The following is a description of a gene set: Human Gene Set: GOBP_POSITIVE_REGULATION_OF_INTRACELLULAR_SIGNAL_TRANSDUCTION species: Homo sapiens Any process that activates or increases the frequency, rate or extent of intracellular signal transduction., and this is the list of marker genes: GDF5, ERBB2, RAF1, RB1CC1, TLR4 (toll like receptor 4), IKBKG, SNW1, MID2, UCN, S100A4, F2RL1, BMP5, ERBB4, SLC8A2, CD27, LRRK2, GAREM1, CARTPT, IRAK4, MUL1, IL18, GPS2, SERPINA12, NFAT5, PTK2, MAP2K6, TGFB2, FPR2, AR, ADGRV1, AGER, VDR, LIF, FLCN, CASP8, GPNMB, BTK, BBC3, KNL1, EGFR (epidermal growth factor receptor), PTBP1 (polypyrimidine tract binding protein 1), PTPRC, RPL11, NMNAT1, ATR, PECAM1, MARCHF5, NGF, TRIM26, EGF, ARFGEF1, PRXL2C, CDCA8, HTR6, SLC9A1, FYN, MN1, KLHDC10, CARD10, C1QBP, CRACR2A, ING4, TNFSF11, MIF, ENG, PARK7 (Parkinsonism associated deglycase), ERFE, PIP4P1, ALS2, EEF1E1, SLAMF1, CUL3 (cullin 3), KL, BMP6, RICTOR, MADD, DSTYK, ATOH8, CDK5RAP3 (NCBI Gene Id 92989), FGF21, MAP2K1, TICAM2, PPM1A, PTPN11, OASL, FRMD1, DCN, TRIM5, XIAP, C1QTNF4, DOK4, SEMA4D, LATS2, PUM2, CCN2, FGB, TNFRSF1A, FRMD6, MOS, ZBTB7B, RPS7, PIAS4 (protein inhibitor of activated STAT 4), ADORA1, ATAT1, ADCYAP1, PDGFB, LMO3, TPBG, CCL5, WLS (NCBI Gene Id 79971), SHISA5, PIK3CG, HAND2, GDF7, CTNNB1, GADD45B, SMARCA4, CD3E, GUCA1A, MFHAS1, TRIM13, NLRP3, SPRING1, MMP2, MYOC, WNT7B, NPY, HDAC6, RASSF2, TLR8, FAM110C, PPP3CC, HDAC3, IRAK1, MIR126, C5AR1, SIRT1 (sirtuin 1, NCBI Gene Id 23411), TFG, NTS, DVL3, GADD45G, MTDH, TERF2IP, RPS6KB1 (NCBI Gene Id 6796), ABCA7, SH2B1, KLF2, S100A13, MAP4K1, STK39, DDX60, MBIP, DDR2, HLA-DRB1, TRIM22, PTPRJ, GSDME, AJUBA, BOK, LILRA5, GJA1, NOTCH2, BANK1, SEMA5A, TRAF6, FN1, CASTOR1, PSMA6, JUND, P2RX7, AMH, FGF19, FGA, AGT, DIRAS2, MIR181D, TRIM32, ALOX15, NR2C1, GNAI2, EXTL3, STK4, CARD9, COL3A1, PAK1, KIAA0319, IQGAP3, ABRA, IL1A, TWSG1, PDCD4, USP9X, BCLAF1 (BCL2 associated transcription factor 1), LIN28A, PRKD2, FLT1, TP53BP1, CASP1, RWDD3, ATP2C1, P2RX4, SLC30A10, HTR2B, BMPR1A, USP32, LGALS9, ALOX12B, FGF17, ADIPOQ, RET, IL6, AKT1, MIR181A2, CSNK1A1, CHI3L1, PRKACA, CLEC6A, SASH1, CLU, EDN3, PRKCE, FNIP2 (NCBI Gene Id 57600), SHOC2, STK25, GFRAL (NCBI Gene Id 389400), NOD2, USP17L2, CCR1 (C-C motif chemokine receptor 1), LMCD1, RAP1B, PTPN6, BCL10, MAP3K7, VAV2, BRCC3, SESN2 (sestrin 2), MARCO, RTKN2, CD4, NRXN1 (neurexin 1), TAB3, FABP5 (NCBI Gene Id 92424), UBE2N, ATF6, MIR182, ARHGEF10, MERTK, S100A12, GPR37L1, SEMA3E, HCST, CCR7, AGO3, NPY5R, GPR62, CAT, F11R, DUSP19, IGFBP5, RPS20, MLST8, VAV1, PELI2, FLT3, GPR55, LRRC19, RIT2, SOX2, RASGEF1A, PIM1, FGFR4, FLOT2, HAVCR2, BMP2, SPPL3, TRIM55, IGF2, FXR1 (FMR1 autosomal homolog 1), PYCARD, CBL, PDGFD, DDX1, TAOK1, GBP2, LAMTOR1, EPO, MYD88, GREM1, CYP27B1, CXXC5, PDE8A, PML, PDGFC, IL19, VAPA, DKK1, LAMTOR5, HTT, KMT2D, PLXNB1, PROS1, ADORA2A (adenosine A2a receptor), MAP3K11, PRL, PTPN22, DGKQ, DDX5, BMPR2, DDT, SPECC1L (sperm antigen with calponin homology and coiled-coil domains 1 like), MALT1, CAV2, CHRNA7, WNT4, ADCYAP1R1, RACK1, MSX1, YWHAE, KSR1, PELI1, MYC, IL1R1, SLCO3A1 (solute carrier organic anion transporter family member 3A1), DDR1, ZDHHC3, FNTA, MARK4, BMP4 (bone morphogenetic protein 4), IKBKE, GPR137, TRPV4, PLPP3, SLC19A1, CSF3, RC3H2, CLEC7A, FGF8, WBP2, SOX11, NELFE, MAPRE2, CRKL, MAPK8IP1, PRKD1, ZDHHC5 (NCBI Gene Id 25921), PLA2G2A, TGFBR2, ACTN4 (NCBI Gene Id 81), TXN, IL11, OTUB1, HIP1, TNS3, DRD5, KLHL22, ADRA2C, AVPR1B, GOLPH3, P2RY1, TGFA, ALOX15B, NAGK, NPPC, CD36, MIR1246, ITGB3, MAPK8, FFAR4 (free fatty acid receptor 4), NOX1, SKP2, KITLG (KIT ligand), GAS6, STMP1, EIF5A, SEH1L, SORBS3, INAVA, FKBP1A, MT3, OTUD5, PPP3R1, CX3CR1, HSPA1A, RASD2, SRARP, DOK7, SFPQ, NLRP12, WNT5A, NRP1, DLG5, BIRC7, USP15, NLGN1, NEDD4, SEMA7A, RELL2, KLB, PRAG1, RRAGD, AVPR2 (arginine vasopressin receptor 2), RNF39, KCNK6, BCAR3, ADRA1B, EZH2, THPO, XBP1, DAB2IP, TLR6, UBE2I, IQCJ-SCHIP1, DRD2, NPR1, ITGB1, LIMS1, XRCC3, VWF, ERP29, RNF31, TNFRSF10B, GATA3, RYK, PDCD10, IGFBP3, SCT, MIR27A, CCL3, ITGB1BP1, CD81, SLC38A9 (solute carrier family 38 member 9), NMUR1, BIRC3, C1QTNF12, IRF3, PMAIP1, CDON, PLAGL2, MIR21 (NCBI Gene Id 406991), GADD45A, HFE, ERN1, SECTM1, GPER1, HSPA1B, CSF1R, MED1, TNFSF14, ARRB2 (arrestin beta 2), CARD11, TEK, TRIP6 (thyroid hormone receptor interactor 6), SELP, GPRC5B, TYRO3, PDE6H, CCL21, FGF4, KIT, DDRGK1 (NCBI Gene Id 65992), FGF1, ZAP70, TMEM9B, MID1, APOL3, CORO7 (coronin 7), PTPN1, REL, BAD, AKR1C2, DVL2, WDFY1, TNFRSF19, FGF10, WAC, GPR101 (NCBI Gene Id 83550), TRIM56, RTN4, TIFA, TRAF2, FRMD7, DDIT3, FGFR3, EPHA4, MAP3K20, MAP4K4, APP, CFLAR, MC1R, CD44 (CD44 molecule (IN blood group)), MYDGF, GPR37 (G protein-coupled receptor 37), SERPINF2, FGF3, TMEM33, FZD7, TGFBR1, LAPTM5, RUNDC3A, RBCK1, BAK1, TLR3, NCK2, BMP10, FERMT2, RHEB, INHBA, ECM1, ALKAL2, ATM, HTR2C, CD19, RRAGB (NCBI Gene Id 10325), PROK1, EPGN, F3, EP300, APOA1, HIC1, NOTCH1, TRIM38, RSAD2, LAMTOR4, HCRTR1, DDX3X, GRM5, MAP3K4, GHRL, SLC15A4, ARHGAP6, FBXW7, NUP62, NUP93, CIB1, TGM2, F10, UBB, P2RX2 (purinergic receptor P2X 2), PRMT1, TLR7, VEGFA, FBXW11, TASL, EFNA5, INCENP, MIR23A, FASLG, MIR519D, IRS1, KRAS, PIK3CA, APELA, ITGA1 (integrin subunit alpha 1), SAMTOR, FGF20, CDH5, FRS2, UNC5B, RPL37, RAP1A, PDPK1, HDAC2, HPSE, PDE6G (NCBI Gene Id 5148), CRK, SHQ1, GPX1, MIOS, RASGRP1, HMOX1, CPNE1, AUTS2, EIF2AK2, NDST1, BECN1, FCRL3 (Fc receptor like 3), NRG1 (neuregulin 1), HTR2A, PIK3R1, FER, GDF2, PIK3AP1, INS, PROX1, RTN4R, FCGR2B, VNN1, RELL1, RC3H1, GAB1, ANKRD17, DDX21, PRKCB, SMAD3, ITPKB, STOX1, MAPK8IP2, ILK, TNIP2, TREML4, MIRLET7B, WNT7A, TAOK2, PLA2R1, PLK2, NRK, LPAR1, C10orf71, CDK10, NEK10, BRAF, NMUR2, MIR675, P2RX3, CHD5, BMPER, SOD1, CLEC16A, GCG, SKIL, RRAGA, ADORA2B, MTOR, GUCA1ANB-GUCA1A, PPARD (peroxisome proliferator activated receptor delta), FNIP1, CALR, CCDC22, TGFBR3, EI24, TAOK3, MIR138-1, TNFSF15, IAPP, ACKR3, ZC3HAV1, ECT2, PIK3R5, TPR, F7, LAT, EDN2, GH1, AKT3, MAD1L1, GBP5, SMAD4, DUSP15, CRIPTO, PCP4, S100A9, IRAK1BP1, FGF18, CXCL17, SEC13, NEGR1, PRR5L, FLNA, UBD, CAVIN3, TNF, TMEM106A, C1QTNF1 (NCBI Gene Id 81852), F2, P2RY12, SYK, LPAR2, GDF6, TRIM62, CD40LG, TPD52L1, IGFBP4, JCAD, SHC1, CTBP2, EDA, FGF7, CAV1, DHX15, RAMP3, ADRA2B, TIRAP, CSPG4, BNIP2, GUCY1A1, CDKN2A, NDFIP1, CHUK, TRADD (NCBI Gene Id 8717), STK3, CCDC88C, ADRB1, VAV3, MIR186 (microRNA 186), TFRC, CARD14, BIRC5, MST1R, TRIM25, SCHIP1, NPSR1, AXL, MIR27B, BCAP31, HRAS, EDAR, ACVR1, RPS3, PPP5C (protein phosphatase 5 catalytic subunit), LTB (NCBI Gene Id 4050), OPRK1, RRAGC, PAGR1, TOR2A, ABL1, DYNC1LI1 (dynein cytoplasmic 1 light intermediate chain 1), LPAR3, LTA, STK19, GHR, ADAM9, LITAF, RNF183 (NCBI Gene Id 158260), MAPKBP1, UBE3A, SOS1, ZC3H12A, OSM, RAPGEF2, STAT3, FGR, KSR2, DHX58, SEPTIN4, MCF2L, UNC5CL, TAB2, STAMBPL1, GAPDH, CSNK2B, TNFRSF11A, ROCK1 (Rho associated coiled-coil containing protein kinase 1), DRD4, IFI35, MIR199A1, MIR181B1, MINK1 (NCBI Gene Id 50488), PICALM, CD86, MAPK3, FLOT1, ADISSP, TIFAB (TIFA inhibitor), SH3RF1, TICAM1, FGF6, LACRT, PRKRA, HBEGF, ASXL1, ERBB3, LCK, TTI1, NCK1, NET1, ARHGAP8, NMI, BMP7, SPRED1, MAP2K3, PRKN, FOXA1, TRAF5, CHP2, CALCR, CCL4, WWC1, SH3RF2, DOK5, TGFB3, IQGAP1, RIPK3, LGALS1, LRP4, ADRA1A, ARL6IP5, CSF1, BST2, NAMPT (NCBI Gene Id 10135), PTK2B, SH3RF3, ZDHHC1, FGF9, EFNA1, MIR24-1, TMEM100, TMEM101, ELANE, IGF1R, HGF, BCL2L11, FADD, JAK2, NDC80, TLR9 (NCBI Gene Id 54106), PLCG2 (phospholipase C gamma 2), IGFBP6, CITED2, SCIMP, CCL19, JUN, PTEN, RXRA, TLR2, TP73, TTK, SPATC1L, RAC1, CHERP, FGFR2, ZNF268 (zinc finger protein 268), CC2D1A, CCDC88A, TRAT1, ZDHHC13 (zinc finger DHHC-type palmitoyltransferase 13), BTBD10, TTI2, CTNS, HIPK2, VCP, MEF2C, JMJD8, ICAM1, LTK, SLC20A1, IGF1, NAIP, MCL1, ZNF622, CDC42, IL23A, SLC44A2, TREM2, RGL2, PDGFRA, S100A7 (NCBI Gene Id 6278), MIR16-1, IL26, MAP4K2, EDNRB, ALPK1, TRAF3IP2, MTCH2, PTGIS, SPRY2, TAF1, ADRA2A, RIPK1, PTPN2, CASR, AXIN1, ZNHIT1, NTRK3, HUWE1, NTF3, PSG9, LURAP1L, PRKCZ, GPR137C (G protein-coupled receptor 137C), PJA2, SDCBP, BAG4, F2R, MAZ, ANKRD6, IL6R, ADRA1D, FGF5, PIM2, AGR2, MAP3K12, FGF2, WDR24, NACC2, OR2AT4, TENM1, NDFIP2, SIK3, ALKAL1, LEP, AURKB, PIH1D1, NOD1, LAMTOR2, PDE8B, FGFR1, ZNF385A, RHOC, HINT1, CA8, ADTRP, ADRB2, CLEC4D, GEN1, CASS4, ADA, PUM1, LTF, NTRK2, OTUD7B, GOLT1B, TRIM8, ITGAV, P2RX5, FIS1, BID, CDH2, FGF22, BAX (NCBI Gene Id 581), DUSP22, SEMA3A, LYN, USP50, PAQR3, NDRG4, INSR, FBH1, OGT, ZDHHC17 (zinc finger DHHC-type palmitoyltransferase 17), ANGPT1, ARRDC3, MMD2, ZCCHC3, PLCB1, NTRK1, SYNPO2L, GCNT2, ASXL2, CD40, PLEKHG5, IL1B, PPP1R15A, PRR5, TGFB1, TELO2, PPIA, SYT14P1, S100A8, AKAP12, CDH13, CTH, TP53, UBE2V1, GDF15, TSPAN6 (NCBI Gene Id 7105), AKR1C3, PDGFRB, MTURN, MIR29A, NEK7, GPR89A, DNAJC27, VEGFB, SPI1 (NCBI Gene Id 6688), THRB, PTP4A3, CDKL5, CASP10, RBX1 (NCBI Gene Id 9978), MAD2L1, MIR15A, NENF, NEK6, ROR1, RHOA (NCBI Gene Id 387), KDR, MAP3K3, MAPK8IP3, GRM1, MAT2A, CANT1, MAP3K10, P2RY6, ARRB1, ACVR2A, AARS1, RPTOR, GPR183, FLT4, AGO1, SERINC3, GUCY1A2, IRS2, MAP2K7, APOE, ROCK2, CD74, IFIT5, SHARPIN, TRIM16, THBS1, FSHR, IL12B, IL20RA, SIAH1, CARD16, IL18R1, HCLS1, TRIM52, PINK1, ADAM8, TSPYL5, STYXL1, PPP2CA, BRD4, DRD1, NDP, TNIK, TRIM15, EDA2R, AMBRA1, ARHGEF3, MIR96, MAVS, GPR155, DHX33 (NCBI Gene Id 56919), PYHIN1, RPL26, ROBO1, EPHA8, DHX36, CX3CL1, FGF23, TCF7L2, IL34, NCKAP1L, SPRED2, TIAL1, TRIM3 (tripartite motif containing 3), DSC2, PHB1, SPHK1, MAP3K5, GDF11, THRA, TMED4, RELN, ADRB3, GLIPR2, PHB2, AKAP13, EDNRA, CD28, RNF167, PRNP, SEMA4C, NEUROD2, GPBAR1, LRRK1, HMGB1, ZDHHC9, NHERF1, LTBR, TNFSF10, ARHGEF5, CRH, GLCE, NKD1, GPR137B, CAMTA1, PLA2G1B, MIB2, SMCR8 (NCBI Gene Id 162633), SLC35B2, OPRM1, TCIM, LAMTOR3 (late endosomal/lysosomal adaptor, MAPK and MTOR activator 3), IRAK2, LARS1, USP4, ANKRD1, RNF13, TRAF7, ACVRL1, RAD9A, PRDX2, LURAP1, DENND2B, NOX4, HEXIM1, NR3C2, SLC46A2, PPP3R2, SCARB1, RPL23, MIER1 (NCBI Gene Id 57708), HDAC1, MYORG, PIK3R6, NPPA, PRKCA, MIR92A1, NUPR1, TBX1, AKAP6, TBK1, NECAB2, ADCY10, PPP3CB, CUL1, TAB1, TRAF4, NKX3-1, IRAK3, AVPI1, DIRAS1 (DIRAS family GTPase 1), WDR59, SLC15A3, SRMS, MAS1, OSBPL8, ADGRG1, TNFAIP8L3, ACTA2, NODAL, RASGRF1 (Ras protein specific guanine nucleotide releasing factor 1), CCAR2, RPS15, PLA2G5, NPNT, DAB2, PPP3CA, PRP4K, SPAG9 (NCBI Gene Id 9043), RIPK2, PDGFA, PIK3CB (phosphatidylinositol-4,5-bisphosphate 3-kinase catalytic subunit beta), C18orf32, WNT16, TAF6, TRIM44, GRM2, PARP1, HAX1, BIRC2, AKAP5, S100B, IKBKB, RELA, GPR4, NR2C2, FGF16, LATS1, FGG, EDN1, SRC, FZD10, RXRB, GRM4